The following is a description of a gene set: A catalytic activity that acts on a histone protein. Reversible histone modifications contribute to regulation of gene expression. species: Homo sapiens Human Gene Set: GOMF_HISTONE_MODIFYING_ACTIVITY, and this is the list of marker genes: NAA60, FBXL19, RSBN1, USP51, PYGO2, HDAC3 (NCBI Gene Id 8841), KAT6B, PHF8, HUWE1, SETDB1, JMJD6, KDM4D, ING3, MEAF6, KDM7A, PRDM9 (NCBI Gene Id 56979), PRDM7, BRCA2, KDM1A, PRMT7, SETDB2, BAP1, KDM1B, KDM4F, BRCA1, CDY2A, UBR2, HR, METTL23, GTF2B, TADA2A, NCOA3, MAP3K7, HAT1, PHF2, PKN1, SETD7, ATF2, TAF9, RNF168, JMJD1C, USP3, SETD1B, HIPK4, PRMT5, UHRF1, SMYD1, HDAC1, PRMT9, JADE2, CREBBP, KAT2A, CARM1, USP22, NAA40, EYA1, JAK2, KDM6B (lysine demethylase 6B), PRKDC, SETBP1, SETMAR, SETD4, USP36, KMT2A, SMYD3, MSL2, GTF3C4, PHF10, BUB1, SRCAP, HDAC8, PRDM16, KDM6A, SMYD2, KMT5A, MYSM1, EYA2, KAT6A, BAZ1B, CDK2, RNF2, PRMT2, PKM, BRPF1, BRD1, HDAC2, PRKAA1, BAZ1A, DCAF1, TAF10, KDM5D, PRDM2, PADI4 (peptidyl arginine deiminase 4), UTY, KDM4C (NCBI Gene Id 23081), EYA3, TAF1, NSD1, ING4, ASH1L, CHEK1, KMT2B, FBLL1, PRMT3, MECOM, KDM4A, DOT1L, KAT8, RNF20, SMYD5, PRMT1, KMT2C, KDM3A, TAF1L, NAP1L2, KDM2A, KMT5B, PADI2, EP300, AURKA, RPS6KA4, NCOA1, CDY1, KDM5C, KMT2D, CDK1, FBL, BARD1, EHMT2, KAT2B, PRKCB, EZH2, NTMT1, RIOX2, DYRK1A, RIOX1, SIRT1, N6AMT1, KAT14, CDY1B, PRMT8, RPS6KA5, SUV39H1, USP16, NSD2, KMT5C, SETD2, PRDM6, HASPIN, KAT5, TTLL12, WDR5, KAT7, JADE1, JARID2, SETD3, KDM4E, PRMT6, KMT2E, PCGF3, SETD1A, TRIM37, KDM8, KDM5A (NCBI Gene Id 5927), PRDM13, VRK1, PRDM8, BRPF3, ARRB1, ATM, PCGF5, ATR (NCBI Gene Id 57307), TGM2, KDM2B, KDM3B, NSD3, EHMT1, SUV39H2, MCM3AP, KDM4B, USP49, SETD5 (NCBI Gene Id 55209), CLOCK, CDY2B, PRKAA2, DTX3L, PRKCA, KDM5B, NAA50, EZH1